The following is a description of a gene set: Human Gene Set: MODULE_576 Genes in the cancer module 576. species: Homo sapiens, and this is the list of marker genes: SLC25A16, PTMA, SETDB1, H4C14, CDC42SE2, SLC25A1, PPP4R1, HYOU1 (hypoxia up-regulated 1, NCBI Gene Id 10525), PPP2R5C, PTBP1, PRSS3, WNT5B, CKB, RNF11 (ring finger protein 11), TMEM97, DLK1, KLK6, SLC20A1, PNLIP, GABRA2, TYMP, RPLP2, DPAGT1, SARM1, TBC1D2B, TXNDC16, LIMCH1, PLAUR, MECP2, DLL1, CCDC88A, DHODH, MYH11, MYO1C, CRNKL1, MPPE1, HGD, CHORDC1, WWP1, MYLK2, EID1, LSM14A, NUP54, TAGLN3, RHAG, SSR3, MARCKS, KDM5D, MLF1, ZNF217, CBY1, NF2, TRIM4, ELL, AUP1, GLRX, VASH2, PLPBP, CTNNAL1, IL1R1, SLC9A1, CC2D2A, LEAP2, SMYD5, SRP14 (signal recognition particle 14), DBNDD1, RNF4, H3-3B, NXN, COL16A1, TECPR2 (NCBI Gene Id 9895), LYN, KLHDC10, PFDN4, TNFRSF14, PRDM1, ATG5, MTMR2, BMP2, PPP2R5D, RNASEH2C, MARF1, SLC25A37, ACACB, MKNK2, NNT, KPTN, OXR1, LIMS3, ADA, ZNF667, NINJ1, ME2, FKBP1B, CD14, LAMTOR1, MGAT3 (NCBI Gene Id 4248), CCN3, ALG12, NNMT, TRAF6, PDGFRA, ACTA1 (actin alpha 1, skeletal muscle), LHX2, EXOSC4, PCGF3, CLIC4, FOXS1, GATM, GC